The following is a description of a gene set: Comprehensive identification of all functional elements encoded in the human genome is a fundamental need in biomedical research. Here, we present a comparative analysis of the human, mouse, rat and dog genomes to create a systematic catalogue of common regulatory motifs in promoters and 3' untranslated regions (3' UTRs). The promoter analysis yields 174 candidate motifs, including most previously known transcription-factor binding sites and 105 new motifs. The 3'-UTR analysis yields 106 motifs likely to be involved in post-transcriptional regulation. Nearly one-half are associated with microRNAs (miRNAs), leading to the discovery of many new miRNA genes and their likely target genes. Our results suggest that previous estimates of the number of human miRNA genes were low, and that miRNAs regulate at least 20% of human genes. The overall results provide a systematic view of gene regulation in the human, which will be refined as additional mammalian genomes become available. Human Gene Set: RYCACNNRNNRNCAG_UNKNOWN species: Homo sapiens Genes having at least one occurrence of the highly conserved motif M128 RYCACNNRNNRNCAG in the regions spanning 4 kb centered on their transcription starting sites. The motif does not match any known transcription factor binding site. from publication Xie X, Lu J, Kulbokas EJ, Golub TR, Mootha V, Lindblad-Toh K, Lander ES, Kellis M (PMID 15735639), and this is the list of marker genes: NEUROD2, FLYWCH1, IL17RE, SP8, PDZD2, KRT73, TSC22D3, CLVS1, STARD13, RRAGA, NADK2, FBXO11, UPK2, GPR156, ODF1, SUSD1, C3orf49, EGR3, EMX2, CHRDL1, PLEKHA6, UBE2L3, ARX, TBC1D21, SOX12, FGF13, CALB1, ARTN, LEMD2, PBXIP1, MEF2C, STEAP1, ASIC1, CD79B, SLC25A4, RPP25L, LINC03122, BLOC1S1, JOSD2, ITSN2, RHOF, STEAP1B, STAT3, PPP1R21, TLE3, KLHDC10 (NCBI Gene Id 23008), PLXNA2, LDB2, FAAP20, MDK (midkine), COX14, TPM3, FYB1, DLGAP4 (DLG associated protein 4), MACROH2A1, LINC01089, RHOC, CYBC1, ELMO3, NIPBL, NPFF, FAM89B, GPR173, PHLDB1, AHCYL2, CPNE1, NR5A1, FRMD4A, WNT10B, PITPNM1, CSRNP3 (cysteine and serine rich nuclear protein 3), PPP3CB, FMR1, MB, CHST13, SEMA3A